The following is a description of a gene set: Human Gene Set: GOBP_CHLORIDE_TRANSPORT species: Homo sapiens The directed movement of chloride into, out of or within a cell, or between cells, by means of some agent such as a transporter or pore., and this is the list of marker genes: CLIC1, CASR, GABRA3, GLRA1, SLC12A9, CLCA1, SLC12A2, ANO9, GABRR2, WNK4, CLCN6, PRKG2, CLIC2, GABRR3, ABCB1, ATP8B1, CLCNKA, FXYD1, SLC4A1, GABRB2, ANO3, SLC12A4, P2RY4, KCNK1, SLC4A8, SLC1A4, GABRA2, ANO1, SLC12A7, SLC6A2, CLIC3, SLC12A5, SLC4A10, CLDN17, CLCN2, BEST4, SLC26A6, ANO6, SLC26A3, LRRC8A, GABRA4, BEST3, GABRB3, BEST2, SLC12A3, GLRB, NMUR2, CLIC6, CLIC4, BEST1 (bestrophin 1), SLC17A6, SLC26A2, GABRE, KCNK2, SLC1A7, SLC6A1, CLIC5, SLC26A10P, SLC5A8, OSTM1, TMC4, GABRB1 (NCBI Gene Id 2560), TTYH2, ANO10, AQP6, ANO7, SLC26A11, UCP2, OCA2 (NCBI Gene Id 4948), CLCA4, CLCN5, GABRA6, CLCN1, ANO8, SLC26A9, GABRG2, SLC5A1, ANO4, GABRD, CLCN3, SLC4A9, SLC4A3, SLC25A14, SLC12A1, CLCNKB, P2RX5, CLNS1A, SLC1A1, GABRG3, FXYD3, TTYH1, BSND, SLC17A7 (solute carrier family 17 member 7), GABRP, P2RY6, SLC26A5, MFSD8, SLC12A6, GLRA3, APOL1, SLC26A1, CLCN7, GABRA1 (NCBI Gene Id 2554), SLC6A14, SLC12A8, CLCN4, ANO5, NMUR1, TTYH3, GLRA2, CFTR, GABRR1, CLDN4, SLC1A3, GABRG1, SLC26A7, SLC26A8, SLC4A2, GABRQ, CLCA2, GABRA5, TSPO, CA7, SLC17A8, PACC1, CLCC1, SLC25A27, CA2, ANO2, SLC26A4